The following is a description of a gene set: studied in species Homo sapiens Palmar hyperlinearity Human Gene Set: HP_PALMAR_HYPERLINEARITY Exaggerated skin markings (dermatoglyphics) on the palms of the hand., and this is the list of marker genes: ALOX12B, CYP4F22, CERS3, ALOXE3, KDF1, STS, FLG